Given this list of marker genes HMGCR, H19, CCL5, S100A9, CYP2C19, NR1D2, here is a description of the gene set: Genes down-regulated by telomere shortening due to the knockout of TERC in the presence of chronic liver damage. Human Gene Set: WIEMANN_TELOMERE_SHORTENING_AND_CHRONIC_LIVER_DAMAGE_DN from publication Wiemann SU, Satyanarayana A, Buer J, Kamino K, Manns MP, Rudolph KL (PMID 15608677) studied in species Mus musculus Telomere shortening limits the regenerative capacity of cells during aging and chronic disease but at the same time inhibits tumor progression, and it has yet to be determined which of these mechanisms is dominantly affecting organismal survival. Here we show that telomere shortening in telomerase knockout (mTERC-/-) mice in combination with chronic liver damage significantly reduced organismal survival even though telomere shortening strongly inhibited liver tumor formation. Decreased survival induced by telomere shortening correlated with an imbalance between liver cell proliferation and liver cell apoptosis. Specific changes in gene expression were associated with telomere shortening and chronic liver damage and these gene expression changes were partially reversed by adenovirus mediated telomerase gene delivery. This study gives experimental evidence that the negative impact of telomere shortening on organ homeostasis and organismal survival can surpass the beneficial effects of telomere shortening on suppression of tumor growth in the setting of chronic organ damage.